The following is a description of a gene set: Genes up-regulated in spleen follicular B lymphocytes: wildtype versus IRF8 knockout. studied in species Homo sapiens from publication Feng J, Wang H, Shin DM, Masiuk M, Qi CF, Morse HC 3rd (PMID 21178004) Conditional IRF8 KO mice (mice with a conditional allele of Irf8 crossed with CD19-Cre mice) showed increased numbers of both Gene expression data spleen marginal zone (MZ) and Gene expression data spleen follicular (FO) B cells compared to control mice. To evaluate gene expression patterns that distinguished FO or MZ B cells derived from conditional KO and control mice, we used Affymetrix GeneChip® Mouse gene 1.0 ST Array. Human Gene Set: GSE24972_WT_VS_IRF8_KO_SPLEEN_FOLLICULAR_BCELL_UP, and this is the list of marker genes: TBCE, KNTC1, SLC35B2, LELP1, DHRS13, ORC5, RBPMS2, RHOF, DLGAP5, GALNT14, ACSL3, LIX1, N4BP3, KCTD11, CKM (creatine kinase, M-type), SDC1 (NCBI Gene Id 6382), DVL2, AGGF1, RPS6KC1, RNF11, SSR1, FGF17, UBE2R2, PDPN, INKA1, CD276, UCHL1, ETV1, VN1R5, PJA1, SPATA19, PWWP2A (PWWP domain containing 2A), APOC3, RILP, FTMT, MTHFD1L, PSMA4, KCNJ9, IFIT2, ZBTB37, ZNF644, MCM10, GINS2, LRIT1, CNGA1, GJA8, PLAC8, BPIFA1, CYP4A11, TOX2, FZD1, CPEB4, CERS6, JARID2, CD3E, BTG4, TMEM178A, PKP2, ASXL2, CD2AP, TLE6, ATP9B, CYP3A7, SOX7, E2F2, EPHA6, PHLPP1, IKZF3, NAA11, ADNP, LRRC75A, PLA2G4D, MAGEB5 (MAGE family member B5, NCBI Gene Id 347541), INKA2, DHCR7, USP5, DIO2, GLMN, VPS13A, ARMCX6, KIF13A, CYP4X1, DNAH11, RAPGEF5 (Rap guanine nucleotide exchange factor 5), RASSF4, EXOC7, OLFM1, DCST2, LYL1, ELOVL6, SGMS2, PER3, KLF2, GSTM1, TIA1, DOCK11 (NCBI Gene Id 139818), SPATA16, AGO1, CYB5R2, ACO1, ARHGAP4, SEMA4A, C18orf54, FASN, GIMAP4, IGHM, MTO1, ACAP1, FDFT1, PTGIS, DPYS, SPG11, ENO1, IL1RAPL2, MARVELD2, MET, STEAP4, TSPO2, DUBR, PRKAR2B, RGS7BP, PM20D1, DUSP6, VSIG10, CXCR6, LLCFC1, SLC9A3, PSRC1, TXNRD3, NUP50, CYP51A1, FN1, PPP2R1B, OTP, UBASH3A, PCDH7, PLG, EPB41L1, NRCAM, AP1M1 (adaptor related protein complex 1 subunit mu 1), IRX5, ILF3, IL2RB, TBC1D2B, PRRT1, SLC25A36, WDR73, ZNF385B, NIBAN3, NLRP6, PRELID2, PPHLN1, HIVEP3, APEX1, DBX2, KHDRBS2, DLGAP2, SRRD, C2CD5, CD3G, DHCR24, QNG1, COPRS, DUOX1, ZIC4, MYOF, HNRNPUL1, SLC38A10, CLTRN, DENND3, PLD4, LAT, RFC2, MELK, NUBP1 (NUBP iron-sulfur cluster assembly factor 1, cytosolic), H1-2, NDUFA9, RSL24D1, CUL9, SGSM2, FAM83D, PIGH, DMWD, LAMB3, PAFAH1B3 (NCBI Gene Id 5050), IDH2, TSC1, GFOD1, GRHL3, NES, QDPR (quinoid dihydropteridine reductase), MAP4K1, PLCG2, TNFRSF13C, ANO9, ERCC6, OTX1